The following is a description of a gene set: In order to obtain a comprehensive picture of the molecular events regulating cutaneous photodamage of intact human epidermis, suction blister roofs obtained after a single dose of in vivo ultraviolet (UV)B exposure were used for microarray profiling. We found a changed expression of genes. Half of the UVB-regulated genes had returned to pre-exposure baseline levels at 72 h, underscoring the transient character of the molecular cutaneous UVB response. Of special interest was our finding that several of the central p53 target genes remained unaffected following UVB exposure in spite of p53 protein accumulation. We next compared the in vivo expression profiles of epidermal sheets to that of cultured human epidermal keratinocytes exposed to UVB in vitro. We found genes that differed in their expression profiles between the two groups. The expression profile in intact epidemis was geared mainly towards DNA repair, whereas cultured keratinocytes responded predominantly by activating genes associated with cell-cycle arrest and apoptosis. These differences in expression profiles might reflect differences between mature differentiating keratinocytes in the suprabasal epidermal layers versus exponentially proliferating keratinocytes in cell culture. Our findings show that extreme care should be taken when extrapolating from findings based on keratinocyte cultures to changes in intact epidermis. Genes down-regulated in NHEK cells (normal epidermal keratinocytes) after UVB irradiation. Human Gene Set: ENK_UV_RESPONSE_KERATINOCYTE_DN studied in species Homo sapiens from publication Enk CD, Jacob-Hirsch J, Gal H, Verbovetski I, Amariglio N, Mevorach D, Ingber A, Givol D, Rechavi G, Hochberg M (PMID 16434974), and this is the list of marker genes: ATP2A2, GCSH, LAMP3, KDM5A (NCBI Gene Id 5927), STX6, HSPE1, HNRNPD, RABGAP1, NMI, CTCF, FASN, IGSF3, ARL6IP5, NCOA3, BMI1, PUM2, PYROXD1, JAG2, PSPH, ENTPD6 (ectonucleoside triphosphate diphosphohydrolase 6), UBE4A, MBD2, RBM8A, TOP2B, IFT25, TFAP4, RPP30, SEC24B, CELSR2, BAIAP2, AGL, OGT, ATRX (NCBI Gene Id 6475), ABCE1, TRIM38, KAT6A, CNN3, GOLGA4 (NCBI Gene Id 2803), TBXA2R, CEBPD, GBE1, DUSP5, MTMR4, BPTF, ITSN2, RACK1, PRKCI, PKD2, PPP2R5E, TOMM20, MAN2A1, PAFAH1B1, UTP3, SYPL1, FMR1, ELP1, FLRT2, RAB14, SEC23A, H2AZ2, VAMP4, PEX6, TGDS, HNRNPA0, RUVBL1, ARHGEF4, TBL2, PSMG1, YES1, ZFR (zinc finger RNA binding protein), SIAH1, PTMA, ACADSB, ERCC5, DDX42, IMPA1, COL16A1, UBE2C, CTNNAL1, ACYP1, TERF1, CPOX, GCAT, ADCY9, TOR1A, SUGP2, SEMA3C, CDC123, GNE, KATNB1, PSMD5, TRIM23, SRI, CBX1, MAOA, RARS1, ITGB5, GAS2L1, ZFAND5, PEX3, TJP2, PAWR, CRIM1, ID1, SP100, EFEMP1, C1D, DOP1B, PTP4A2, TNFRSF1A, SLBP, SLC2A3, GSDME, CSNK1A1, ZNF146, IFI44L, SRSF1, KLF9, GOSR1, TUSC2, ADRB2, RXYLT1, RPGR, CTBP1, NBN, ATXN2, CYB5B, BCAR3, BLMH, PGRMC2, SVIL, SLC2A1, CRADD, IFI44, AFAP1, DUT, BCAT2, RGS19, PRH1, STK3, MALT1, EPS15, ATP1B3, SCML2, RB1, TMEM187, DNAJA1, URI1, DUSP4, RABIF, TCERG1, UBE2D3, SUMO1, TRA2B, GTF2F2, NPTN, USP7, ABCC5, ATP2C1, CD58, IFIT1, ACTR2, CBX3, MCM6, FNTB (farnesyltransferase, CAAX box, subunit beta), SEMA3F, EID1, STARD7, FAT1, MSMO1, ZNF638, PIP4K2B, MBD4, GNPAT, GOLGA8A, WASF1, ZWINT, IPO5, SLC16A1, STRN3, ELAC2, DCAF8, ZDHHC3, CYP51A1, CSE1L, DLEU1, NAE1, FDFT1, STAU1, XPA, GSK3B, AKAP10, PLSCR1, BCL6, PTPN1, TRIP12, CTNNA1, RTCA, WWTR1, ZNF133, CREB1, NOL7, TSNAX, CLIP1, UBA2, DHX9, ZMYND8, NOLC1, MCL1, TRIM13, KIFAP3, DEK, TARBP1, STEAP1, SMARCA2, IPO7, CNOT4, CLTC, PRPF4, EIF3J, MTF2, RP2, DLG5 (discs large MAGUK scaffold protein 5), TP63 (NCBI Gene Id 8860), MAPKAPK5, DHRS3, WWOX, MKRN1 (NCBI Gene Id 392799), GNAQ, NME6, CDC23, SNX7, TYMS, PFKM, CPSF4, RASA1, FPGT, BET1, PEX11B, HNRNPR, YAF2, UPF3A, AGPS, RO60, YME1L1, ANXA7, ERH, FEN1, PRKDC, RGS2, AZIN1, ACBD3, DHX15, IGF2BP3, HOXA9, RRM1, MICB, MED7, CAMKK2, STXBP3, PCMT1, SERPINE2, CNTN1, NRG1, USP6, RBMX, MTHFD1, MDH1, RGS20, ELOVL5, DKK1, YTHDC1, RAPGEF5, RNF13, DDX3Y, SNRPG, TM9SF2, ADH5, MACF1, SLC35A1, PPP1R3C, PRRG1, SMC1A, ENTPD4, CUL1, MMS19, CDKN1B, TOP2A, HPS5, TACC1, GOT1, EXTL3, EEF1E1, UBR5, SORL1, KLF7, SDHD, TUBGCP2, UGDH, XPO1, MT1H, MYO5A, CCND2, LUC7L3, ACTL6A, CD44, SCAF11, DNMT1, RCBTB2, GMFB, TRIP13, NPEPPS, PAICS, SLC25A5, EIF4H, ATR, LAMP2, MTMR3, SMARCA1, ACADM, SSB, CPD, PRKAR1A, TGFBR2, NIPSNAP2, RPP38, ZMYM2, ENOSF1, CD46, CD2AP, IRS1, ZNF148, CCNG2, CAP2, GRSF1, TCFL5, PHB1, MAD2L1, PTOV1, HNRNPDL, BIRC3, TRIM44, MCM3AP, AKAP11, IL10RB, PCF11, PTPRZ1, ADCY7, VRK1, SCFD1, USP14, VPS26C, PFDN4, CXADR, CNOT2, COG5, IFNGR2, LYST, G3BP2, ANP32A, ADCY3, ATP6V1A, TMX1, RBM6, POLR2B, HES1, PTHLH, H4C3, VSNL1, TPST2, PARP1, ATP5F1B, ACSL3, MARCHF7, TNC (NCBI Gene Id 3371, tenascin C), PAK1, ACTR3, COPB1, RBBP8, ITSN1, MAP4, SMAD4, SQLE, ARHGAP8, TCEAL1, ARFGEF1, TP53BP1, SLC9A6, WNK1, PURA, STT3A, LPCAT3, GAPDH, PCGF3, RABEPK, B4GALT2, MECP2, CDK14, WNT5A, RDX, HSPA4L, ME2, GSK3A, SLC11A2, MARK3, TPX2, ZMYND11, PCDH7, FAT2, HSPD1, BIRC2, MRPL3, UBE2N, COPS2, TLK2, ARHGEF7, RBFOX2, KTN1, BNIP3L, TOPORS, ASH2L, MYO10, FOS, MBNL1, LBR, DKC1, AASDHPPT, AFF1, FOXO3, NDUFS1, BHLHE40, UMPS, SNX4, TENT4A, GTF3C2, SRF, FZD6, RNF2, DLD, RND3, FH, PPIG, CPNE3, CUX1, AFG3L2, H1-0, CDK2, EPRS1, CDC7, PRP4K (pre-mRNA processing factor kinase PRP4K), KIF2A, G3BP1, CCDC6, FKBP5, FEZ1, MPHOSPH6, PIK3R3, MAP3K5, SNTB2, RPA3, MIA2, EBAG9, ROCK2, DDX17, PICALM, RANBP2, DYRK2, TPR, AUH, SNRPF, SRSF11, SFRP1, KHSRP, CETN3, NMT2, SNRNP200, SLC31A1, BRD8, BUB3, KRAS, USP1